The following is a description of a gene set: Binds to and modulates the activity of a sodium channel. Human Gene Set: GOMF_SODIUM_CHANNEL_REGULATOR_ACTIVITY species: Homo sapiens, and this is the list of marker genes: SNTA1, RANGRF, NEDD4, FGF12, FXYD6P3, YWHAH, ANK3, GLRX, GPD1L, GPLD1, FXYD2, FXYD4 (FXYD domain containing ion transport regulator 4), PTPN3, PKP2, TMEM168, RSC1A1, CAMK2D, TMPRSS3, FGF14, NEDD4L, C8orf44-SGK3, FXYD5, FXYD3, SCN3B, FXYD7, COMMD1, SCN1B, FGF11, SCN2B, SGK2, FGF13, AGT, SGK1, NOS1, PCSK9, ATP2B4, SCLT1, FXYD1, SGK3, SCN4B (sodium voltage-gated channel beta subunit 4), FXYD6, CAV3